Given this list of marker genes AP3D1 (NCBI Gene Id 8943), CACNA1F, AP3B1 (NCBI Gene Id 8546), LYST, MYO5A, GPR143, RAB27A, here is a description of the gene set: Human Gene Set: HP_ABNORMALITY_OF_DERMAL_MELANOSOMES studied in species Homo sapiens Abnormality of dermal melanosomes An abnormality of the melanosomes, i.e., of the cellular organelles in which melanin pigments are synthesized and stored within melanocytes (the cells that produce pigment in the dermis).